Given this list of marker genes DNAI2, SNX20 (sorting nexin 20), PCNA, ATF3 (activating transcription factor 3), TP53INP1, TNFRSF10C, APP (NCBI Gene Id 351), E2F7, TYMSOS, ZNF597, DNAI3, HAS3, PPM1D, BLOC1S2, B2M, PHLDB3, PLK3, AEN, POLH, VWCE, OR11A1, SH2D2A, NOTCH1, BBC3, GADD45A, NINJ1, GDF15, BTG2, FAS, CDKN1A, RHOXF2, ACER2, GASK1B, HSPA4L, COQ9, RRAD, CAVIN2, MDM2, CHADL, FDXR, PLCL2 (phospholipase C like 2), LRATD2, DDB2, BEX3, SESN1, TIGAR, GDNF, FBXW7, PIDD1, THSD1, here is a description of the gene set: from publication Warters RL, Packard AT, Kramer GF, Gaffney DK, Moos PJ (PMID 19580510) Genes up-regulated in the human skin cells at 4 h after exprosure to 5 Gy dose of ionizing radiation. Human Gene Set: WARTERS_IR_RESPONSE_5GY species: Homo sapiens Although skin is usually exposed during human exposures to ionizing radiation, there have been no thorough examinations of the transcriptional response of skin fibroblasts and keratinocytes to radiation. The transcriptional response of quiescent primary fibroblasts and keratinocytes exposed to from 10 cGy to 5 Gy and collected 4 h after treatment was examined. RNA was isolated and examined by microarray analysis for changes in the levels of gene expression. Exposure to ionizing radiation altered the expression of genes across both cell types. Changes in RNA expression could be arranged into three main categories: (1) changes in keratinocytes but not in fibroblasts, (2) changes in fibroblasts but not in keratinocytes, and (3) changes in both. All of these changes were primarily of p53 target genes. Similar radiation-induced changes were induced in immortalized fibroblasts or keratinocytes. In separate experiments, protein was collected and analyzed by Western blotting for expression of proteins observed in microarray experiments to be overexpressed at the mRNA level. Both Q-PCR and Western blot analysis experiments validated these transcription changes. Our results are consistent with changes in the expression of p53 target genes as indicating the magnitude of cell responses to ionizing radiation.